Given this list of marker genes Imp3, Tesc, Itpkb, Cd3e, Hint1, Chd4, Ppm1m, Ppdpf, Nt5c, Tox, Tceal9, Ccdc88c, Sh3bgrl3, Ephx1 (NCBI Gene Id 98277), Tecpr1, Psen2, Timm13, Fyb1, Pfn1, Hnrnpa3, Myh9, Tubb5, Anapc5, Ahnak, Fxyd5, Uqcc5, Pcm1, S100a11, Dpm3, Ift20 (NCBI Gene Id 68335), Crip1, Lamtor4, Ifi27, H1f4, Capns1, Cd3g, Ftl1, Rasgrp1, Cbx3, Cdk2ap2, H2az2, Galnt1, Cd3d, Hmgb1, Septin1, Scd2, Pin4, Ncor1, Cd81, Bri3, Cxcr4, Cd44, Atp5if1, Gnai2, Tspan32, Izumo1r, S1pr1, H2az1, Ucp2, Mrpl33 (NCBI Gene Id 66845), Abca2, Entrep3, Fuca1 (NCBI Gene Id 78549), Il27ra, Pwwp3a, Acp5, Pdcd4, Ypel3, Glipr1, Rac2, Cfl1, Cotl1, Nmb, Ski, Fkbp3, Higd2a, Ndufb11 (NADH:ubiquinone oxidoreductase subunit B11), Use1, Actn1, Klf6, Acot13, Gimap3, Bnip3l, Rab24, H3f3a, Rgs2, Dusp1 (NCBI Gene Id 98098), Vcf1, H2aj, Rgs19, Ramp1, Lsm5, Sars1, Elof1, Rasgrp2, N4bp2l1, Tiam1, Pdrg1, Mettl26, Id3, Cd52, Dad1, Kmt2c, Thap3, Itga4, Gpx1, Tmem258, Rgs10, Uqcr11, Npm1, Ctdsp2, Ssr4, Macf1, Gstp3, Arhgap45, Srpk2, Prdx5, S100a10, Chchd10, Rabac1, Glg1, Vim, Septin11, Hnrnpul1, Fth1, Pold4, Arhgdib, Gpx4, Pou2f2, Sh3kbp1, Anp32b, N4bp2l2, S100a13, Thy1, Bola2, Ddx17, Glrx5, Hcfc1, Ssbp3, Add3, Atp6v1f, Trappc4, Tspan13, Emp3, Rexo2, Eif3i, Sugt1, Akt1, Acyp1, Stap1, Appl1, here is a description of the gene set: from publication Cui A, Huang T, Li S, Ma A, Pérez JL, Sander C, Keskin DB, Wu CJ, Fraenkel E, Hacohen N (PMID 38057668) Cytokines mediate cell-cell communication in the immune system and represent important therapeutic targets. A myriad of studies have highlighted their central role in immune function, yet we lack a global view of the cellular responses of each immune cell type to each cytokine. To address this gap, the authors created the Immune Dictionary, a compendium of single-cell transcriptomic profiles of more than 17 immune cell types in response to each of 86 cytokines (>1,400 cytokine-cell type combinations) in mouse lymph nodes in vivo. A cytokine-centric view of the dictionary revealed that most cytokines induce highly cell-type-specific responses. For example, the inflammatory cytokine interleukin-1β induces distinct gene programmes in almost every cell type. A cell-type-centric view of the dictionary identified more than 66 cytokine-driven cellular polarization states across immune cell types, including previously uncharacterized states such as an interleukin-18-induced polyfunctional natural killer cell state. Genes negatively differentially expressed in cell type: Treg upon treatment with cytokine: IFN-α1 in mouse lymph nodes in vivo. species: Mus musculus Mouse Gene Set: CUI_TREG_IFNA1_RESPONSE_DN